The following is a description of a gene set: from publication Liberzon A, Birger C, Thorvaldsdóttir H, Ghandi M, Mesirov JP, Tamayo P (PMID 26771021) Genes specifically up-regulated in pancreatic beta cells. studied in species Homo sapiens Human Gene Set: HALLMARK_PANCREAS_BETA_CELLS, and this is the list of marker genes: LMO2, G6PC2, GCK, NEUROG3, PAX6, HNF1A, SEC11A, SLC2A2, GCG, NEUROD1, CHGA, PCSK1, INS, PKLR, SCGN, PAK3, SST, IAPP, SRP14, ELP4, SRP9, AKT3, FOXA2, SPCS1, PCSK2, ABCC8, DCX, MAFB, VDR, INSM1, ISL1, PAX4, NKX6-1, NKX2-2, SRPRB, PDX1, SYT13, STXBP1, FOXO1, DPP4